Given this list of marker genes Ywhab, Scaf4, Rtf1, Nedd4, Pcif1, Sfn, Ywhaz, Scaf8, Pin1, Ywhae, Leo1, Pin1rt1, here is a description of the gene set: species: Mus musculus Mouse Gene Set: GOMF_PHOSPHOSERINE_RESIDUE_BINDING Binding to a phosphorylated serine residue within a protein.